The following is a description of a gene set: Human Gene Set: WANG_NFKB_TARGETS studied in species Mus musculus from publication Wang H, Hertlein E, Bakkar N, Sun H, Acharyya S, Wang J, Carathers M, Davuluri R, Guttridge DC (PMID 17438126) NF-kappaB signaling is implicated as an important regulator of skeletal muscle homeostasis, but the mechanisms by which this transcription factor contributes to muscle maturation and turnover remain unclear. To gain insight into these mechanisms, gene expression profiling was examined in C2C12 myoblasts devoid of NF-kappaB activity. Interestingly, even in proliferating myoblasts, the absence of NF-kappaB caused the pronounced induction of several myofibrillar genes, suggesting that NF-kappaB functions as a negative regulator of late-stage muscle differentiation. Although several myofibrillar promoters contain predicted NF-kappaB binding sites, functional analysis using the troponin-I2 gene as a model revealed that NF-kappaB-mediated repression does not occur through direct DNA binding. In the search for an indirect mediator, the transcriptional repressor YinYang1 (YY1) was identified. While inducers of NF-kappaB stimulated YY1 expression in multiple cell types, genetic ablation of the RelA/p65 subunit of NF-kappaB in both cultured cells and adult skeletal muscle correlated with reduced YY1 transcripts and protein. NF-kappaB regulation of YY1 occurred at the transcriptional level, mediated by direct binding of the p50/p65 heterodimer complex to the YY1 promoter. Furthermore, YY1 was found associated with multiple myofibrillar promoters in C2C12 myoblasts containing NF-kappaB activity. Based on these results, we propose that NF-kappaB regulation of YY1 and transcriptional silencing of myofibrillar genes represent a new mechanism by which NF-kappaB functions in myoblasts to modulate skeletal muscle differentiation. Representative genes up-regulated in C2C12 cells (myoblast) lacking NFkB activity due to expression of a super repressor form of NFKBIA., and this is the list of marker genes: TNNC1, ITGB5, MIOX, CASP7 (caspase 7), MYH1, CSRP3, TNNI1, ACTC1, MYH7, MYL4, MEF2B, NOTCH1, TRAF5, SH3BP1, HOXA1, FOXA2, CISH, APLNR, CHRNG, CMA1, ATP2A1, CAV3, TNNT1, RARG